Given this list of marker genes Lsr, Shroom3, Srp19, Litaf, Retreg1, Serp1, Lcn2, Ebp, Nucb2 (nucleobindin 2), Lrrfip1, Dsg2, Aldoc, Atp6v1a, Ss18l2, Dap, Atp6ap2, Wwc1, Cldn3, Chmp2b, Ell2, Xbp1, Timd2, Cyb561, Irx3 (NCBI Gene Id 16373), Irf6, Fxyd3, Arhgef5, Golph3, Cldn7, Galnt3, Kcnn4, Id2, Rnf149, Spint1, Strbp, Crybg1, Sox4, Cd82, Plet1, Cmas, Acsl4, Slc66a2, Tfap2c, Tpd52, Ehf, Vdr, here is a description of the gene set: from publication Landis MD, Seachrist DD, Abdul-Karim FW, Keri RA (PMID 16434967) studied in species Mus musculus Genes up-regulated in preneoplastic mammary tissues and whose expression is maintained in tumors. Epidemiological studies indicate that parity enhances HER2/ErbB2/Neu-induced breast tumorigenesis. Furthermore, recent studies using multiparous, ErbB2/Neu-overexpressing mouse mammary tumor virus (MMTV-Neu) mice have shown that parity induces a population of cells that are targeted for ErbB2/Neu-induced transformation. Although parity accelerates mammary tumorigenesis, the pattern of tumor development in multiparous MMTV-Neu mice remains stochastic, suggesting that additional events are required for ErbB2/Neu to cause mammary tumors. Whether such events are genetic in nature or reflective of the dynamic hormonal control of the gland that occurs with pregnancy remains unclear. We postulated that young age at pregnancy initiation or chronic trophic maintenance of mammary epithelial cells might provide a cellular environment that significantly increases susceptibility to ErbB2/Neu-induced tumorigenesis. MMTV-Neu mice that were maintained pregnant or lactating beginning at 3 weeks of age demonstrated accelerated tumorigenesis, but this process was still stochastic, indicating that early pregnancy does not provide the requisite events of tumorigenesis. However, bitransgenic mice that were generated by breeding MMTV-Neu mice with a luteinizing hormone-overexpressing mouse model of ovarian hyperstimulation developed multifocal mammary tumors in an accelerated, synchronous manner compared to virgin MMTV-Neu animals. This synchrony of tumor development in the bitransgenic mice suggests that trophic maintenance of the mammary gland provides the additional events required for tumor formation and maintains the population of cells that are targeted by ErbB2/Neu for transformation. Both the synchrony of tumor appearance and the ability to characterize a window of commitment by ovariectomy/palpation studies permitted microarray analysis to evaluate changes in gene expression over a defined timeline that spans the progression from normal to preneoplastic mammary tissue. These approaches led to identification of several candidate genes whose expression changes in the mammary gland with commitment to ErbB2/Neu-induced tumorigenesis, suggesting that they may either be regulated by ErbB2/Neu and/or contribute to tumor formation. Mouse Gene Set: LANDIS_BREAST_CANCER_PROGRESSION_UP